The following is a description of a gene set: Genes up-regulated in T98 cells (glioma) 48 h after treatment with interferon beta. Human Gene Set: NATSUME_RESPONSE_TO_INTERFERON_BETA_UP from publication Natsume A, Ishii D, Wakabayashi T, Tsuno T, Hatano H, Mizuno M, Yoshida J (PMID 16140920) Alkylating agents, such as temozolomide, are among the most effective cytotoxic agents used for malignant gliomas, but responses remain very poor. The DNA repair protein O6-methylguanine-DNA methyltransferase (MGMT) plays an important role in cellular resistance to alkylating agents. IFN-beta can act as a drug sensitizer, enhancing toxicity against a variety of neoplasias, and is widely used in combination with other antitumor agents such as nitrosoureas. Here, we show that IFN-beta sensitizes glioma cells that harbor the unmethylated MGMT promoter and are resistant to temozolomide. By means of oligonucleotide microarray and RNA interference, we reveal that the sensitizing effect of IFN-beta was possibly due to attenuation of MGMT expression via induction of the protein p53. Our study suggests that clinical efficacy of temozolomide might be improved by combination with IFN-beta using appropriate doses and schedules of administration. species: Homo sapiens, and this is the list of marker genes: FGF5, HRK, CALM2, IL11RA, FGF9, EIF2AK2, CREM, TNFSF14, DST, MAPK1, MAP3K14, TLX1, KDM5A, CASP7, HLA-B, FASLG, NFKB1 (NCBI Gene Id 4790), HSPA4, TP53BP2, CLK2, CXCL9, STAT1, IGFBP5, APAF1, NFATC2, PPARA (peroxisome proliferator activated receptor alpha), VCAM1, EPHB3, HSPA9, RGS2, MAP2K6, DNAJA1, ICAM2, FOSL2, RPGR, TP53, TRAIP, FGF10, ETV4, AKT1, IFNG, DDIT3, CHST15, HSP90B1, TGFBR3, IL15RA (NCBI Gene Id 3601), TFF1, AMPD2, FAS, PDGFA, MC4R, SFPQ, NCOR1, IGFBP3 (insulin like growth factor binding protein 3), MMP7, PTPRZ1, IFITM3, ENO3, CDK13, TIMP3, BCL3, HLA-C, IRF1, PER2, MAPK10, BCL2L2, IGF2, GRB14, CASP9, IL18